The following is a description of a gene set: Human Gene Set: GOBP_POSITIVE_REGULATION_OF_RELEASE_OF_SEQUESTERED_CALCIUM_ION_INTO_CYTOSOL Any process that activates or increases the frequency, rate or extent of the release into the cytosolic compartment of calcium ions sequestered in the endoplasmic reticulum or mitochondria. studied in species Homo sapiens, and this is the list of marker genes: NTSR1, BDKRB1, HTT, P2RY6, AKAP6, APLNR, TRPC1, F2, CXCL9, SRI, IL13, HAP1, GSTO1, CX3CL1, CEMIP, CXCL10, CXCR3, SNCA, LACRT, PDPK1, JPH2, F2R (coagulation factor II thrombin receptor), PLCG1, F2RL3, CASQ1, THY1, CD19, CAPN3, GPER1, XCL1, DRD1, BAX, CXCL11, NPSR1, ABL1